The following is a description of a gene set: Abdominal cramps studied in species Homo sapiens Human Gene Set: HP_ABDOMINAL_CRAMPS A type of abdominal pain characterized by a feeling of contractions and typically fluctuating in intensity., and this is the list of marker genes: ASXL1, RUNX1, CBL, SRSF2, MNX1, POLG, TYMP, TET2